The following is a description of a gene set: Human Gene Set: GSE17974_IL4_AND_ANTI_IL12_VS_UNTREATED_72H_ACT_CD4_TCELL_UP Genes up-regulated in comparison of CD4 T cells treated with IL4 and anti-IL12 at 72 h versus the untreated cells at 72 h. species: Homo sapiens from publication Elo LL, Järvenpää H, Tuomela S, Raghav S, Ahlfors H, Laurila K, Gupta B, Lund RJ, Tahvanainen J, Hawkins RD, Oresic M, Lähdesmäki H, Rasool O, Rao KV, Aittokallio T, Lahesmaa R (PMID 20620947) The aim of this dataset was to study in detail the transcription kinetics initiated by cytokine IL-4 in early differentiation of Th2 cells., and this is the list of marker genes: TEX36-AS1, PRSS58, TRIM10, KIRREL3-AS3, CASQ2, IFT80, ZNF488, CRISP2, UNC50, TMEM245, SH3BGR, MMEL1, CLDND1, ANO8, CARNS1, DSG1, EML2, CAMK1, IL4R, AOAH, ZMYM4, ETFB, CYP3A7 (NCBI Gene Id 1551), MGST3, BMS1P1, NSMCE1, TMC8, PECAM1, ECH1, ENSG00000223438, LINC02003, SCPEP1, NIPA1, CD3G, DLG5, OAZ2, HOMER2, IL10RA, ZC3H8, LIN7C, TMEM102, ATP6V0A2, POU2F3, KRT1, PLEKHH2, IL17RB, CAPN13, PDE7B (NCBI Gene Id 27115), OGDHL, EFNA5, MCRS1, YKT6, GKN1, AKAP12, DPY19L3-DT, CACNB4, TRIM51, IL1RN, RASSF8, TRPC5, SPAG17, PPP1R14A, ID2, SLC25A31, PLA2G2D, SUN2, SPINT2, ENTPD1-AS1, IVD, EOMES, NDFIP2, CCDC86, GNAI1, ATXN1, SLC39A2, ADGRV1, LRRC28, TRH, TRIM29, IGSF3, RNF138, ZMYND8, BIN2, SHISA5, MS4A12, SHLD1, RAB27B, LINC03025, PGLYRP2, IKZF2, MAGEA12, USP35, PTGIS, TCTA, PDE9A, ANKRD36C, ZBTB38, C15orf39 (NCBI Gene Id 56905), JAML, ALPL, UPRT, RPA4 (replication protein A4), TMEM234, ADGRE2, MRPS26, SLC52A2, CTNS, TSEN54, MAOB, PHLDA1, PTDSS1, KIF26A (kinesin family member 26A), OR5I1, RRS1, EVI2B, ENDOD1, TMEM71, VIPR2, LRRC32, PTPRA, C21orf91-OT1, FAM110C, PTPN14, GPR183, KCNK5 (NCBI Gene Id 8645), IFT70A, HTR2B, TPRG1, LIMA1, MRPS6, CXCL11, BEX3, CD164, GAB2, RNF125, SNHG28, ELAPOR2 (NCBI Gene Id 222223), TRIM67 (NCBI Gene Id 440730), DUSP6 (dual specificity phosphatase 6), PLXDC1, MMP12, PTPN3, ABCD3, LINC01550, ZNF589, GSTA3, LGI1, LINC01560, MYO3B, GATA3, ADGRA3, PLA2G4A, PTEN, SVOP, GDE1, IFFO2, CES4A (carboxylesterase 4A), CXorf51A, ZC3HAV1L, LRRC37BP1, GOLGA8A, MLLT11, ANKH, NMU, MAOA, SHOC1, THRA, GPR146, CLDN1, AGAP12P, GATD1, S100P, QRICH2, SYTL3, KCTD16, PNPLA3, SERINC5, ACTR3BP2, MAL, SETBP1, SMAD2, VSIG10L, ZNF423, TIMP1